Given this list of marker genes ENPP1, GJB6, POU3F4, NOG, IL11RA, ABCC6, GJB2, RAD21, here is a description of the gene set: species: Homo sapiens Human Gene Set: HP_STAPES_ANKYLOSIS Stapes ankylosis refers to congenital or acquired fixation of the stapes (the stirrup-shaped small bone or ossicle in the middle ear), which is associated with conductive hearing resulting from impairment of the sound-conduction mechanism (the external auditory canal, tympanic membrane, and/or middle-ear ossicles). Stapes ankylosis